Given this list of marker genes Apc, Rab11a, Rab11fip3, Pard6a, Cep72, Gsk3b, Nup62, Ubxn2b, Mark4, Nsfl1c, Bicd1, Cep250, here is a description of the gene set: species: Mus musculus Mouse Gene Set: GOBP_REGULATION_OF_PROTEIN_LOCALIZATION_TO_CENTROSOME Any process that modulates the frequency, rate or extent of protein localization to centrosome.